The following is a description of a gene set: Mouse Gene Set: GOMF_D_GLUCOSE_SODIUM_SYMPORTER_ACTIVITY Enables the transfer of a solute or solutes from one side of a membrane to the other according to the reaction: D-glucose(out) + Na+(out) = D-glucose(in) + Na+(in). studied in species Mus musculus, and this is the list of marker genes: Slc5a11, Slc5a9, Slc5a4a, Gm5134, Slc5a1, Slc5a2, Slc5a10, Slc5a4b (solute carrier family 5 (neutral amino acid transporters, system A), member 4b), Slc5a3